The following is a description of a gene set: Cytokines mediate cell-cell communication in the immune system and represent important therapeutic targets. A myriad of studies have highlighted their central role in immune function, yet we lack a global view of the cellular responses of each immune cell type to each cytokine. To address this gap, the authors created the Immune Dictionary, a compendium of single-cell transcriptomic profiles of more than 17 immune cell types in response to each of 86 cytokines (>1,400 cytokine-cell type combinations) in mouse lymph nodes in vivo. A cytokine-centric view of the dictionary revealed that most cytokines induce highly cell-type-specific responses. For example, the inflammatory cytokine interleukin-1β induces distinct gene programmes in almost every cell type. A cell-type-centric view of the dictionary identified more than 66 cytokine-driven cellular polarization states across immune cell types, including previously uncharacterized states such as an interleukin-18-induced polyfunctional natural killer cell state. from publication Cui A, Huang T, Li S, Ma A, Pérez JL, Sander C, Keskin DB, Wu CJ, Fraenkel E, Hacohen N (PMID 38057668) Mouse Gene Set: CUI_PDC_IL1A_RESPONSE_UP Genes positively differentially expressed in cell type: pDC (plasmacytoid dendritic cell) upon treatment with cytokine: IL-1α in mouse lymph nodes in vivo. studied in species Mus musculus, and this is the list of marker genes: Fkbp5, Gsr, Ctnnd2, Csf2rb2, Sla2, Socs3, Rab27a (NCBI Gene Id 75673), Epha2, Flt3, Cyth1, Pim1, Ddit4, Ccnd3, Paqr5 (progestin and adipoQ receptor family member V), Syngr2, P2ry10, Bcl3, Cycs, Rnf19b, Klf13 (Kruppel-like transcription factor 13), Ppp1r21, Cd200r1, Bcl11a, Prkca (protein kinase C, alpha), Sdc3, Ptpn1, Cebpb, Ddr1, Myl6, Slc15a3, Fam43a, Hck, Cd38, Gpr171, Srsf5, Adpgk, Gpr18, Zfp36l2, Rftn1, Klk1b27, Grb2, Casp3, Cfl1, Pfkp, Ppp1r16b, Gpr55, Cd82, Eif1, Selplg, Ubl3, Ssu72, Trim30d, Rbm3, Gpx4, Slamf9, Tsc22d3, Dad1, Ptprc, Atp2b4 (ATPase, Ca++ transporting, plasma membrane 4), Ifi204, Lefty1, Sub1, Ly6a, Cytip, Atp5f1d, Fbl, Lifr (LIF receptor alpha), Hat1, M6pr, Runx1, Rilpl2, Fam241a (family with sequence similarity 241, member A), Slc7a5, Psma7, Napsa, Srgn, Ifnar1, Gpr85, Slc30a4, Bcl2l11, Phf11b (NCBI Gene Id 236451), Klk1, Nme1